Given this list of marker genes GLUD2, GLUD1, PYCR1, RIMKLB, GLS, GOT2, GLUL, ALDH18A1, PYCR3, OAT, GLS2, PYCR2, RIMKLA, KYAT1, here is a description of the gene set: These reactions mediate the synthesis of glutamate and glutamine from ammonia and TCA cycle intermediates and allow the utilization of the carbon atoms from these amino acids for glucose synthesis under fasting conditions. These reactions also provide a means to collect nitrogen, both as ammonia and as amino groups, and direct it towards urea synthesis. Transamination, the conversion of an amino acid to the corresponding alpha-keto acid coupled to the conversion of a molecule of 2-oxoglutarate (alpha-ketoglutarate) to glutamate, is the first step in the catabolism of most amino acids. Transamination reactions are freely reversible so they also provide a means to balance concentrations of various amino acids and 2-oxo (alpha-keto) acids in the cell. Reactome Pathway: Glutamate and glutamine metabolism part of: Metabolism of amino acids and derivatives species: Homo sapiens